The following is a description of a gene set: part of: Opioid Signalling This event has been computationally inferred from an event that has been demonstrated in another species.<p>The inference is based on the homology mapping from PANTHER. Briefly, reactions for which all involved PhysicalEntities (in input, output and catalyst) have a mapped orthologue/paralogue (for complexes at least 75% of components must have a mapping) are inferred to the other species. Reactome Pathway: G-protein activation species: Mus musculus electronically inferred by orthology from the curated human pathway, and this is the list of marker genes: Gng10, Gngt2, Gnb5, Gnb2, Pomc, Gng8, Gng3, Gng4, Gngt1, Gng5, Gnb3, Gng7, Gng11, Oprm1, Gna14